The following is a description of a gene set: Reactome Pathway: Metabolism of non-coding RNA species: Homo sapiens The term non-coding is commonly employed for RNA that does not encode a protein, but this does not mean that such RNAs do not contain information nor have function. There is considerable evidence that the majority of mammalian and other complex organism's genomes is transcribed into non-coding RNAs, many of which are alternatively spliced and/or processed into smaller products. Around 98% of all transcriptional output in humans is non-coding RNA. RNA-mediated gene regulation is widespread in higher eukaryotes and complex genetic phenomena like RNA interference are mediated by such RNAs. These non-coding RNAs are a growing list and include rRNAs, tRNAs, snRNAs, snoRNAs siRNAs, 7SL RNA, 7SK RNA, the RNA component of RNase P RNA, the RNA component of RNase MRP, and the RNA component of telomerase. part of: Metabolism of RNA, and this is the list of marker genes: NUP155 (NCBI Gene Id 9631), SNRPD2, SNRPG, SNUPN, GEMIN2, NDC1, NUP35, NUP58, GEMIN8, NUP98, SEH1L, GEMIN5, NUP43, SMN1, TPR, NUP214, NUP210, CLNS1A, NUP54, NUP107, GEMIN6, DDX20, NCBP1, SNRPE, RANBP2, rep, NUP62, SEC13, NUP153, SNRPF, NUP42, SNRPB, NUP85, GEMIN4, NUP93, POM121C, TGS1, NUP205, PRMT5, SNRPD1, GEMIN7, POM121, SNRPD3, NUP37, NUP188, RAE1, NUP160, AAAS, NUP88, PHAX, WDR77, NCBP2, NUP133, NUP50